The following is a description of a gene set: The chemical reactions and pathways resulting in the formation of sphingomyelin, N-acyl-4-sphingenyl-1-O-phosphorylcholine. studied in species Mus musculus Mouse Gene Set: GOBP_SPHINGOMYELIN_BIOSYNTHETIC_PROCESS, and this is the list of marker genes: Osbp, Vapa, Sptlc1, Sgms1, Abca8b, Ormdl3, Pemt, Abca8a (ATP-binding cassette, sub-family A member 8a), Sgms2, Sptlc2, Ormdl1, Samd8